Given this list of marker genes Lhx3, Evx1, Pax6, Shh, Dbx1, Sox1, Sufu, Gli3, Gli2, Dmrt3, here is a description of the gene set: The process involved in the specification of the identity of a cell in a field of cells that is being instructed as to how to differentiate. Once specification has taken place, that cell will be committed to differentiate down a specific pathway if left in its normal environment. species: Mus musculus Mouse Gene Set: GOBP_CELL_FATE_SPECIFICATION_INVOLVED_IN_PATTERN_SPECIFICATION